Given this list of marker genes Zfp281, Hgd, Mllt10, Stt3b, Maml3, Spinkl, Sim1, Syn1, Mmgt1, Cnot6, Emc4, Actg1, Reep1, Trim47, Asah2, Ptger2, Armc8, Hacd2, B020004C17Rik, Retreg3, Tomm5, Erc2, Mpl, Lrrtm1, Efcab14 (NCBI Gene Id 230648), N4bp2l2, Nav1, Tmco1, Abhd5, Dph3, Gnas, Lhx6, Lrrc2, Mc1r, Tnrc6b, Selenop, Ifi213, Sf3b6, Agfg1, Plxna2, AU041133, Ogfrl1, Mmp16, Fut10, Ttc17, Hmbox1, Tnik, Zbtb10, Fgf7, Fbxo8, Vps41, Kcnip4, Kpna3, Tmeff2, Ppp1r1c (protein phosphatase 1, regulatory inhibitor subunit 1C), Eif4e2, Prss59, Edn1, Uhrf2, Arg2 (NCBI Gene Id 11847), Tmem229a, Ythdf3, Creg2, Srgap3, Tada2b, Nphp3, Eef1akmt2 (EEF1A lysine methyltransferase 2), Cdc42bpb, Fbxl5, Large1, Plppr4, Sod2, here is a description of the gene set: from publication Chen Y, Wang X (PMID 31504780) Mouse Gene Set: MIR_3067_5P Genes predicted to be targets of miRBase v22 microRNA mmu_miR_3067_5p in miRDB v6.0 with MirTarget v4 prediction scores > 80 (high confidence targets). species: Mus musculus